The following is a description of a gene set: Human Gene Set: GOBP_NEGATIVE_REGULATION_OF_CELL_DEVELOPMENT Any process that decreases the rate, frequency or extent of the progression of the cell over time, from its formation to the mature structure. Cell development does not include the steps involved in committing a cell to a specific fate. studied in species Homo sapiens, and this is the list of marker genes: NOTCH1, RYK, RAG2, NFATC4, IHH, DLX1, CDK5, MIR146A, BRINP1, GPR137B, CBFB, ID4, CD74, SEMA5A, RNF6, LAG3, IL6, BMP7, PTHLH, NR2E1, SFRP1, TMEM98 (transmembrane protein 98), TLX2, NOG, TSPO, HMGA2, HDAC6, FBN1, LRP4, CD69, LTF, RB1, RFLNA, DTX1, TRPC5, ADIPOQ, TMEM178A, SOX10, VSX2, CAV3, LOXL3, CEBPA, BMP4, SLIT1, ULK1, SORL1, F2, DLX2, TRIM46, TNFAIP6, DRAXIN, TBX21, LGALS1, GPR68, TREM2, INHBA, ABCC8, IFNL1, MDK, MT3, IAPP, PGLYRP3, KCTD11, PTPRS, MIR486-1, TRAK2, WNT7A, MIR21, GPR55, KIAA0319, TMEM176B, PTPN2, NKX6-1, VEGFA (NCBI Gene Id 7422), S1PR3, WNT3, MYC, C1QC, SYT4, MCF2 (NCBI Gene Id 4168), DUSP10, BCL6, NPPC, JAK3, MAP2, CLDN18, PLXNA3 (plexin A3), TRIB1, HLX, CERS2, GATA2, LILRB1, IGF1, FSTL3, TLR4, HOXA7, CDKN2A, MIR137, CTLA4, RGMA, IL17D, IL2, TMEM131L, EFNB3, HMGB3, NKX6-2, THY1, CTNNA1, LILRB3, MIR221, SHB, IL4R, ERBB2, DAAM2, MIR181B1, ZFPM1, B2M, DPYSL5, ATOH1, IFNA2, PRDM16 (NCBI Gene Id 647868), SNAI2, ZBTB7B, SHH, NTRK3, KIFAP3, GSK3B, CR1, SEMA6D, INHA, NF1, GDI1 (GDP dissociation inhibitor 1), TRIM11, TRPC6, BMPR1A, GLI3, RARA, PSEN1, GPR137, VAX1, PROX1, NRARP, NPR2, MIR125B1, PGLYRP1, GSK3A (NCBI Gene Id 2931), IRF1 (NCBI Gene Id 96501), LHX2, TCTA, PITX3, NF2, CFL1, APCS, CEACAM1, PIAS3, SEMA4F, CTDSP1, SOCS5, CDH1, EPHA7, APPL2, TBX6, RTN4, FBXO7, GORASP1, TNF, DNAJB11, DAB1, WNT3A, LDLR, ZC3H12A, IL4, WNT5A, MIR222, ERFE, ID2, HOOK3, FRZB, FSTL4, QKI, NRP1, DCC, REST, SMAD7, FOXJ1, YWHAH, TP53, RTN4R (NCBI Gene Id 96184), ULK2, IL1B, ZC3H8, TSC22D1, RUFY3, MIR181C, FGL2 (fibrinogen like 2), SIRT2, RUNX1, EDNRB, RNF10, SYNGAP1, HES5, TOB2, LRRC17, TNFSF4, CTNNB1, SEMA3G, NODAL, MAG, DYNLT1, EPHB2, CALCA, LYN, IFNB1, TMEM176A, LIN28A, INPP5D, HMGB1, RUNX3, BCL11A, PCM1, WEE2, MAFB, UBASH3B, SPP1, CCL11, ZNF675, PRDX2, FGF13 (fibroblast growth factor 13), SOX11, SEMA6C, ANXA1, SKI, RFLNB, PTEN, IFRD1, NR1D1, ARHGAP4, DLL3, HSPA9, TAOK3, CARTPT, SOCS1, PRTG, SPART, PGLYRP2, FCGR2B, TNFRSF11B, TTPA, CUL4A, PTN, ASCL2, MIR30B, FBXW7, RC3H2, BTG2, TNR, RAPGEF2 (Rap guanine nucleotide exchange factor 2), PAX6, PPP3CA, RC3H1, CCL3 (C-C motif chemokine ligand 3), CLEC12A, PAEP, HLA-G, DIP2B, PIK3R1, TNFSF18, TGFB1, STAT5A, CDKL3, SEMA3F, HES1, FOXP3, TLR3, ZBTB46, DICER1 (NCBI Gene Id 4333), CLEC4G, MYCN, GPR37L1, NTN1, SLC4A2, LILRB4, CDK6, MIR29B1, DRD3, IDH2